Given this list of marker genes Pfkl, Pfkm, Pfkfb4, Hk1, Pfkp (NCBI Gene Id 80680), Rbks, Hk3, Xylb, Pfkfb3, Fggy, Khk, Gck, Hkdc1, Pomk, Nagk, Pfkfb1, Galk2, Galk1, Pfkfb2, Gne (glucosamine (UDP-N-acetyl)-2-epimerase/N-acetylmannosamine kinase), Hk2, here is a description of the gene set: Mouse Gene Set: GOMF_CARBOHYDRATE_KINASE_ACTIVITY studied in species Mus musculus Catalysis of the transfer of a phosphate group, usually from ATP, to a carbohydrate substrate molecule.